The following is a description of a gene set: A SWI/SNF-type complex that is found in post-mitotic neurons, and in human contains actin and proteins encoded by the ARID1A/BAF250A or ARID1B/BAF250B, SMARCD1/BAF60A, SMARCD3/BAF60C, SMARCA2/BRM/BAF190B, SMARCA4/BRG1/BAF190A, SMARCB1/BAF47, SMARCC1/BAF155, SMARCE1/BAF57, SMARCC2/BAF170, DPF1/BAF45B, DPF3/BAF45C, ACTL6B/BAF53B genes. The nBAF complex along with CREST plays a role regulating the activity of genes essential for dendrite growth. species: Mus musculus Mouse Gene Set: GOCC_NBAF_COMPLEX, and this is the list of marker genes: Smarcc1, Dpf3 (NCBI Gene Id 97800), Actl6b, Smarca4, Arid1a, Smarca2, Arid1b (NCBI Gene Id 78879), Actb, Smarcd3, Dpf2, Dpf1, Smarcb1, Smarcd1, Ss18l1, Smarcc2, Smarce1